The following is a description of a gene set: Human Gene Set: GSE9239_CTRL_VS_TNF_INHIBITOR_TREATED_DC_UP Genes up-regulated in monocyte-derived dendritic cells: control versus TNF inhibitor etanercept. from publication Zaba LC, Cardinale I, Gilleaudeau P, Sullivan-Whalen M, Suárez-Fariñas M, Fuentes-Duculan J, Novitskaya I, Khatcherian A, Bluth MJ, Lowes MA, Krueger JG (PMID 18039949) The process for making monocyte derived DCs (moDCs) has been previously described (46). All analysis was performed on “day 5” immature DCs. Etanercept 10mg/mL was added to experimental wells on days 0, 2, and 4. We chose this concentration of etanercept as it approximates the plasma concentration of drug when given 50mg BIW. studied in species Homo sapiens, and this is the list of marker genes: PROS1, PTK2B, CHST12, NPR2, DLG3, TRIP6 (NCBI Gene Id 96624), SLC25A24 (solute carrier family 25 member 24), SAT1, RASGEF1B, CHPF2, RAB20, HSD17B11, CYP2E1, FGD1, TTC38, MRTFA, MTX3 (metaxin 3), GALC, FAM219B, G6PC2, CTRC, DOK1 (NCBI Gene Id 1796), ALDH7A1, CASP12, UBE2R2, RTCB, APPL2, GOSR2, APBB1, SLC29A2, MANF, NAP1L3, CPQ, SNX10 (sorting nexin 10), MPPED2, PLEC, P2RY1 (purinergic receptor P2Y1), HEPH, LSP1, RAD52, RIN2, KANSL3 (NCBI Gene Id 55683), PRR15 (proline rich 15), TNNI3, TAP2, BRD3OS, ALKBH4, TCF25, SUFU, GRINA, ZNF148, HAGHL, PNPLA2, APOBR, NXF1, RAP1GAP2, RNASEL, NDRG2, SIGIRR, CTBP2, ABCA2, CYP1B1 (NCBI Gene Id 1545), FAM217B, HM13, ZDHHC17, PML, HEXA, HSF4, NAGA, SEPTIN8, SDC2, MROH1, BCAS3, SLC12A5, NDRG3, GSTO1, FIBIN, MIDEAS, CPXM1, CLEC4E, ANXA2, DCAF5 (DDB1 and CUL4 associated factor 5), MFGE8, UPP1, LTO1, WTIP, ALDOC, SOX18, INAFM1, WDR19, PEX5L, CSNK1E (casein kinase 1 epsilon), PRSS55, PFKM, BET1L, SERPINF1, TMEM80, TOB1, RNASE6, SPEN, CLU, HOXA10 (NCBI Gene Id 3206), ADI1, CD34, SLC49A4, VAMP2, MYOF, GCLM, ATP6V1G2, ISLR, HMCES, HLA-B, NFIC, MBOAT1, SQLE, PLEKHJ1 (NCBI Gene Id 55111), EXOC6, FAM114A1, MECP2, STK39, UCKL1, BMPR2, GSTM3, SMIM5, ITGA5, FKBP14, TCEAL8, PORCN, PKN3, RNF130, RHBDF1, CC2D2A (NCBI Gene Id 57545), MAPK8IP3, WDSUB1, IL27RA, NFATC4, SLC12A2, BLCAP, DNAJA4, MAPK14, CISH, EXTL3, NUCB1, GIMAP8, EMB, MORN4, BAG6, CATSPER1, UMOD, CREG1, SPO11, TLE5, IFI44, FGFRL1, ITPRIPL2, TNFAIP2, VASP, ELMOD3, TMEM273, TCERG1L, ARHGAP45, ALDH1L1, SMTNL1, DLX3, HLA-DQA1, BDH2, MECOM, INTS6L, SIRT2, ACR, SIAH1, AKAP8L, NBEAL2, MAPK12, PLD4, NBDY, ITIH3, CITED2, ZNF746, DUSP2, GKAP1, BEX4, STX5, CYP4V2, PTOV1, CIAO3, DHRS11, AP3D1, SLC16A12, FBH1, LDHD, IL15, SEC62, MIB2, OAZ2, LAIR1, RNF44, HLA-DRB1, ADGRD1, PGGHG